Given this list of marker genes CDKN1C, RAB34 (NCBI Gene Id 83871), DTWD1, TMEM176B (transmembrane protein 176B), IRF9, VEZF1, FBXL15, PCDH11Y, CHRDL1, MXRA8, DHRS1, PRX, TMEM230, CYLD, SEMA4G, ACP4, CABLES1, ABTB1, IQSEC3, EPPIN, NENF (neudesin neurotrophic factor), YPEL3, F8A1, MAGI2, MAP1LC3A, FGF2, TTLL3, SPR, IFI35, CCR4, CT62, KRT19, CRYAB, C9orf78, OR51B4, SLC16A5, CKB, MAPKAP1, TMEM53, STX5, ALOXE3, GNG7, ECHDC2, PGLYRP1, LYVE1, ZNF446, SPHK2, NCOR2, TMEM98, WFS1, TMEM187, OAS1, UBASH3A, COX7A1, TMEM176A, OTUD5, ANGPTL3, HOXC4, PLAAT4, RBM8A, EXPH5, FAM219B, DLG5, DNAJB12, INPP5A, CCDC97, EPS8L2, TMCO4, SQSTM1, ATXN7 (ataxin 7), DOLK, GNB5, GRB2 (growth factor receptor bound protein 2), RNF167, PDCD1, IFI27L2, LRPAP1, AAK1, ELAC2, SSU72, SLC22A12, CRY2, DNAJC4, PDIK1L, ATP6V1E1, SLC66A3, OR2C1, AMFR, AHNAK, SLC27A1, FES, INMT, NAGLU, PGPEP1, ALDH6A1, SPCS1, here is a description of the gene set: Genes down-regulated in genomically unstable Ewing's sarcoma tumors compared to the stable ones. species: Homo sapiens Ewing's sarcoma (ES) is characterized by specific chromosome translocations, the most common being t(11;22)(q24;q12). Additionally, other type of genetic abnormalities may occur and be relevant for explaining the variable tumour biology and clinical outcome. We have carried out a high-resolution array CGH and expression profiling on 25 ES tumour samples to characterize the DNA copy number aberrations (CNA) occurring in these tumours and determine their association with gene-expression profiles and clinical outcome. CNA were observed in 84% of the cases. We observed a median number of three aberrations per case. Besides numerical chromosome changes, smaller aberrations were found and defined at chromosomes 5p, 7q and 9p. All CNA were compiled to define the smallest overlapping regions of imbalance (SORI). A total of 35 SORI were delimited. Bioinformatics analyses were conducted to identify subgroups according to the pattern of genomic instability. Unsupervised and supervised clustering analysis (using SORI as variables) segregated the tumours in two distinct groups: one genomically stable (< or =3 CNA) and other genomically unstable (>3 CNA). The genomic unstable group showed a statistically significant shorter overall survival and was more refractory to chemotherapy. Expression profile analysis revealed significant differences between both groups. Genes related with chromosome segregation, DNA repair pathways and cell-cycle control were upregulated in the genomically unstable group. This report elucidates, for the first time, data about genomic instability in ES, based on CNA and expression profiling, and shows that a genomically unstable group of Ewing's tumours is correlated with a significant poor prognosis. Human Gene Set: FERREIRA_EWINGS_SARCOMA_UNSTABLE_VS_STABLE_DN from publication Ferreira BI, Alonso J, Carrillo J, Acquadro F, Largo C, Suela J, Teixeira MR, Cerveira N, Molares A, Goméz-López G, Pestaña A, Sastre A, Garcia-Miguel P, Cigudosa JC (PMID 17952124)